The following is a description of a gene set: Mouse Gene Set: GOBP_RESPONSE_TO_CAMP Any process that results in a change in state or activity of a cell or an organism (in terms of movement, secretion, enzyme production, gene expression, etc.) as a result of a cAMP (cyclic AMP, adenosine 3',5'-cyclophosphate) stimulus. species: Mus musculus, and this is the list of marker genes: Kcnq1, Ren1, Cftr, Crtc1, Dgkq, Pik3cg, Rapgef1, Eef2k, Srebf1, Rap1a, Carm1, Duox2, Pklr, Pygm, Ahr, Slc8a1, Pde4d (phosphodiesterase 4D, cAMP specific, NCBI Gene Id 320753), Sdc1, Thbd, Itpr1, Stat1, Pik3r1, Cyp1b1, Pkd2, Rplp0, Ptafr, Fdx1, Igfbp5, Itpr3, Slc26a3, Per1, Ezr, Wnt10b, Gpd1, Rela, Dmtn (NCBI Gene Id 13829), Inhbb, Pde2a, Slc26a6, Inpp5k, Hmgcs2, Duox1, Rapgef3, Hcn4, Aldh3a1, Fosl1, Pck1, Fbp1, Rapgef2, Pnpt1, Areg, Kcne1, Agxt, Akap7, Crhbp, Aqp8, Oxt, Itpr2, Fosb, Aqp1, Hmga1, Crtc2, Gata6, Hcn2, Adipoq, Birc2 (baculoviral IAP repeat-containing 2), Stc1, Star, Fos, Hcn1, Penk, Cdk2, Akap6, Pax4, Rap1b, Crtc3, Slc8a3, Bckdhb, Slc6a3, Ndufs4, Gata1, Aanat, Braf, Cps1, Cdo1, Pfkfb1, Ass1, Ptk2b, Cited1, Lncbate10, Col1a1, Ins1, Tyr, Cnga3, Bsg, Mmp19, Zfp36l1, Vgf, Akap9, Mat2a, Kdm1a, Crem, Cyp27b1